The following is a description of a gene set: studied in species Mus musculus Mouse Gene Set: GOBP_CEREBROSPINAL_FLUID_SECRETION The regulated release of cerebrospinal fluid (CSF) from the choroid plexus of the lateral, third and fourth ventricles. The cerebrospinal fluid is a clear liquid that located within the ventricles, spinal canal, and subarachnoid spaces., and this is the list of marker genes: Trp73, Aqp1, Celsr2, Aqp4, Slc4a5